Given this list of marker genes Igf1, Ddx3x, Syncrip, Jag1, Kat6b, Ncl, Cnn3, Anp32e, Arcn1 (NCBI Gene Id 213827), Prkacb, Picalm, Acvr1, Cpeb1, Arfip1, Ube2h, Smap1, Tbc1d15, Zfp36l2, Coro1c, Plk2, Vamp4, Spred1, Nfat5, Pdcd10, Sec62, Pdcd4, Sec63, Pmp22, Edn1, Gnpda2, Arrdc3, E2f5, Ywhaz, Crem, Fzd7, Hnrnpr, Sf3b1, Atp6v1a, Arf4, Hnrnpk, Arhgap21, Rsbn1, Gclc, Fndc3a, Cited2, Fndc3b, Crim1, Cltc, Efnb2, Gprc5b, Rrbp1, Bdnf, Ywhaq, Tpm3, here is a description of the gene set: Mouse Gene Set: IKEDA_MIR1_TARGETS_UP from publication Ikeda S, He A, Kong SW, Lu J, Bejar R, Bodyak N, Lee KH, Ma Q, Kang PM, Golub TR, Pu WT (PMID 19188439) Calcium signaling is a central regulator of cardiomyocyte growth and function. Calmodulin is a critical mediator of calcium signals. Because the amount of calmodulin within cardiomyocytes is limiting, the precise control of calmodulin expression is important for the regulation of calcium signaling. In this study, we show for the first time that calmodulin levels are regulated posttranscriptionally in heart failure. The cardiomyocyte-restricted microRNA miR-1 inhibited the translation of calmodulin-encoding mRNAs via highly conserved target sites within their 3' untranslated regions. In keeping with its effect on calmodulin expression, miR-1 downregulated calcium-calmodulin signaling through calcineurin to NFAT. miR-1 also negatively regulated the expression of Mef2a and Gata4, key transcription factors that mediate calcium-dependent changes in gene expression. Consistent with the downregulation of these hypertrophy-associated genes, miR-1 attenuated cardiomyocyte hypertrophy in cultured neonatal rat cardiomyocytes and in the intact adult heart. Our data indicate that miR-1 regulates cardiomyocyte growth responses by negatively regulating the calcium signaling components calmodulin, Mef2a, and Gata4. Genes up-regulated in hypertrophic hearts (due to expression of constitutively active form of PPP3CA) and predicted to be targets of miR-1 microRNA. studied in species Mus musculus